Given this list of marker genes DCANP1, GRK2, PDE4D, ACTN3, PDE4B, TIFAB, NEUROG1, here is a description of the gene set: Any process that stops, prevents or reduces the frequency, rate or extent of relaxation of muscle. Human Gene Set: GOBP_NEGATIVE_REGULATION_OF_RELAXATION_OF_MUSCLE species: Homo sapiens